The following is a description of a gene set: Human Gene Set: GOBP_ERBB4_ERBB4_SIGNALING_PATHWAY studied in species Homo sapiens The series of molecular signals initiated by binding of a ligand to the tyrosine kinase receptor ERBB4, followed by ligand-induced homodimerization of ERBB4 and transmission of the signal into the cell by the homodimeric ERBB4 complex. The pathway ends with regulation of a downstream cellular process, e.g. transcription., and this is the list of marker genes: ERBB4, NRG3, NRG4, BTC, EREG, NRG1